The following is a description of a gene set: A vesicular organelle that forms on retraction fibers behind migrating cells and mediates the release of cytoplasmic contents during cell migration. studied in species Homo sapiens Human Gene Set: GOCC_MIGRASOME, and this is the list of marker genes: EPCIP, PKD1, TOMM20, TSPAN9, HSPD1, PKD2